Given this list of marker genes Tfap2a (NCBI Gene Id 21418), Krt12, Twist2, Angptl7, Adamts9, Kera, Sox11, Gsdma3, Pax6, Foxe3, Prickle1, Limk2, here is a description of the gene set: The progression of the cornea over time, from its formation to the mature structure. The cornea is the transparent structure that covers the anterior of the eye. species: Mus musculus Mouse Gene Set: GOBP_CORNEA_DEVELOPMENT_IN_CAMERA_TYPE_EYE